Given this list of marker genes XRCC4, PTGIS, SIRT2, CIDEC, MIR30B, AIFM3, TP53, CASP8, CASP2, DNASE2B, RIPK1, CASP9, BNIP1, NFKBIZ, XKR4, CIDEB, BBC3, CDK5RAP3, ZC3H12A, CIDEA, DNASE1L3, VPS54, BCL2L1, COLEC11, DICER1, TAOK1, BAX, CASP7, IL6, XKR7, GPER1, TOP2A, SHARPIN, DLC1, APAF1, BOK, NPR2, DFFA, CECR2, FASLG, STK24, FZD3, COL6A1, FADD, TRPC5, CASP3, DEDD2, XKR9, FAP, HTRA2 (HtrA serine peptidase 2), EXOG, ERN2 (NCBI Gene Id 388226), MADD, HSPD1, XKR8, TNFRSF1A, DNASE2, CTSD, ACVR1C, MIR15A, AKT1, HTR2A, XKR6, ACIN1, TP53BP2, PLSCR1, GATA5, DFFB, FOXL2, NDUFA13, CXCR3, GCG, NMNAT1, CAPN10, CASP10, ENDOG, BLCAP (BLCAP apoptosis inducing factor), MIRLET7B, CYCS, HSF1, here is a description of the gene set: Human Gene Set: GOBP_EXECUTION_PHASE_OF_APOPTOSIS A stage of the apoptotic process that starts with the controlled breakdown of the cell through the action of effector caspases or other effector molecules (e.g. cathepsins, calpains etc.). Key steps of the execution phase are rounding-up of the cell, retraction of pseudopodes, reduction of cellular volume (pyknosis), chromatin condensation, nuclear fragmentation (karyorrhexis), plasma membrane blebbing and fragmentation of the cell into apoptotic bodies. When the execution phase is completed, the cell has died. studied in species Homo sapiens